The following is a description of a gene set: The process in which the anatomical structures of branches in a nerve are generated and organized. This term refers to an anatomical structure (nerve) not a cell (neuron). Mouse Gene Set: GOBP_BRANCHING_MORPHOGENESIS_OF_A_NERVE species: Mus musculus, and this is the list of marker genes: Drd2, Fgfr2, Epha7, Shox2, Fgf13, Hnrnpk, Map3k13, Rtn4, Lrrk2, Il1b, Bcl11a, Mecp2, Rere, Cpe, Dlx2